Given this list of marker genes PDGFRB, FMNL3, SOX4, FSTL1, NLN, MAP4K4, BCL2, HEG1, MEGF9, EDNRA, TM4SF1, BACE2, here is a description of the gene set: Human Gene Set: CLAUS_PGR_POSITIVE_MENINGIOMA_DN species: Homo sapiens An association between hormones and meningioma has been postulated. No data exist that examine gene expression in meningioma by hormone receptor status. The data are surgical specimens from 31 meningioma patients undergoing neurosurgical resection at Brigham and Women's Hospital from March 15, 2004 to May 10, 2005. Progesterone and estrogen hormone receptors (PR and ER, respectively) were measured via immunohistochemistry and compared with gene expression profiling results. The sample is 77% female with a mean age of 55.7 years. Eighty percent were grade 1 and the mean MIB was 6.2, whereas 33% and 84% were ER+ and PR+, respectively. Gene expression seemed more strongly associated with PR status than with ER status. Genes on the long arm of chromosome 22 and near the neurofibromatosis type 2 (NF2) gene (22q12) were most frequently noted to have expression variation, with significant up-regulation in PR+ versus PR- lesions, suggesting a higher rate of 22q loss in PR- lesions. Pathway analyses indicated that genes in collagen and extracellular matrix pathways were most likely to be differentially expressed by PR status. These data, although preliminary, are the first to examine gene expression for meningioma cases by hormone receptor status and indicate a stronger association with PR than with ER status. PR status is related to the expression of genes near the NF2 gene, mutations in which have been identified as the initial event in many meningiomas. These findings suggest that PR status may be a clinical marker for genetic subgroups of meningioma and warrant further examination in a larger data set. from publication Claus EB, Park PJ, Carroll R, Chan J, Black PM (PMID 18172325) Genes down-regulated in meningioma samples positive for PGR compared to those without the receptor.